The following is a description of a gene set: Human Gene Set: chr1p21 species: Homo sapiens, and this is the list of marker genes: RNU4-75P, SLC30A7, AMYP1, RPL36AP12, TRMT13, AGL, LINC01650, VCAM1, CNN3, RNU6-352P, MIR137, DNAJA1P5, RPSAP19, SNX7, RTCA, RWDD3-DT, AMY1B, ABCD3, AMY1A, CDK4P1, SLC44A3-AS1, RPL23AP90, RN7SKP270, PALMD, MATR3P3, DPH5-DT, S1PR1-DT, LINC01787, GPR88 (G protein-coupled receptor 88), PPIAP7, ENSG00000236098, PTBP2, RPL7P9, DPYD-AS1, LINC02607, PLPPR4 (phospholipid phosphatase related 4), PLPPR5, NFU1P2, DPH5, HNRNPA1P68, RTCA-AS1, LINC01677, OLFM3, CNN3-DT, SEC63P1, MFSD14A, LRRC39, SLC35A3, RPL7AP17, FRRS1, MIR137HG, RN7SKP285, DPYD-IT1, EEF1A1P11, LINC01349, LINC02790, BRI3P1, CDC14A, SEPTIN2P1, DBT, SNX7-DT, F3, BCAS2P2, S1PR1, RPL26P9, HMGB3P10, SASS6, NDUFS5P2, AMY1C, RPL21P26, ENSG00000252765, SLC44A3, UBE2WP1, TLCD4, RN7SL831P, RNU6-965P, DPYD, PLPPR5-AS1, AMY2A, LINC01709, MIR553, LINC01761, THAP3P1, MIR2682, GAPDHP29, KATNBL1P2 (katanin regulatory subunit B1 like 1 pseudogene 2), ACTG1P4, LINC01676, ALG14, AMY2B, DPYD-AS2, LINC01776, ENSG00000289355, RNU1-130P, RWDD3, EXTL2 (NCBI Gene Id 2135), MIR378G, RNU6-750P, FTLP17, ENSG00000299343, COL11A1, SOD2P1, RNPC3-DT, TLCD4-RWDD3 (TLCD4-RWDD3 readthrough), RNU6-1318P, LINC01708, LINC01307, LINC01760, RNPC3